The following is a description of a gene set: species: Homo sapiens part of: RHO GTPase Effectors Reactome Pathway: RHO GTPases Activate ROCKs RHO associated, coiled-coil containing protein kinases ROCK1 and ROCK2 consist of a serine/threonine kinase domain, a coiled-coil region, a RHO-binding domain and a plekstrin homology (PH) domain interspersed with a cysteine-rich region. The PH domain inhibits the kinase activity of ROCKs by an intramolecular fold. ROCKs are activated by binding of the GTP-bound RHO GTPases RHOA, RHOB and RHOC to the RHO binding domain of ROCKs, which disrupts the autoinhibitory fold. Once activated, ROCK1 and ROCK2 phosphorylate target proteins, many of which are involved in the stabilization of actin filaments and generation of actin-myosin contractile force. ROCKs phosphorylate LIM kinases LIMK1 and LIMK2, enabling LIMKs to phosphorylate cofilin, an actin depolymerizing factor, and thereby regulate the reorganization of the actin cytoskeleton. ROCKs phosphorylate MRLC (myosin regulatory light chain), which stimulates the activity of non-muscle myosin II (NMM2), an actin-based motor protein involved in cell migration, polarity formation and cytokinesis. ROCKs also phosphorylate the myosin phosphatase targeting subunit (MYPT1) of MLC phosphatase, inhibiting the phosphatase activity and preventing dephosphorylation of MRLC. This pathway acts synergistically with phosphorylation of MRLC by ROCKs towards stimulation of non-muscle myosin II activity., and this is the list of marker genes: MYL6, RHOA, RHOC, MYL12B, LIMK1, RHOB, ROCK1, PAK1, MYH14, LIMK2, PPP1R12B, CFL1, ROCK2, MYL9, MYH10, PPP1CB, MYH9, PPP1R12A, MYH11